The following is a description of a gene set: species: Mus musculus Any process that activates or increases the frequency, rate or extent of the directed movement of a neurotransmitter into, out of or within a cell, or between cells, by means of some agent such as a transporter or pore. Mouse Gene Set: GOBP_POSITIVE_REGULATION_OF_NEUROTRANSMITTER_TRANSPORT, and this is the list of marker genes: Tacr2, Nlgn1, Syt1, Cacna1d (NCBI Gene Id 97919), Unc13a (NCBI Gene Id 73695), Prkn, Rab3b, Sphk1, Stxbp1, Slc18a3, Micu3, Nat8l, Bglap2 (NCBI Gene Id 12097), Dnm1l, Bglap, Stx1a, Stx1b, Kmo, Gper1, Ptger4, Snca, Rab3gap1, Itgb1 (integrin beta 1 (fibronectin receptor beta)), Adora2a, Dtnbp1, Cacna1b, Drd2, Slc17a8, Gpr158 (G protein-coupled receptor 158), Baiap3, Slc4a8, Bcl2l1, Htr2c